The following is a description of a gene set: part of: DNA Repair This event has been computationally inferred from an event that has been demonstrated in another species.<p>The inference is based on the homology mapping from PANTHER. Briefly, reactions for which all involved PhysicalEntities (in input, output and catalyst) have a mapped orthologue/paralogue (for complexes at least 75% of components must have a mapping) are inferred to the other species. electronically inferred by orthology from the curated human pathway studied in species Mus musculus Reactome Pathway: DNA Double-Strand Break Repair, and this is the list of marker genes: Lig4, Brca1, H4c4, H2bc1, H4c12, Sumo1, H2bc3, Tdp2, Rfc1, H2bc12, H4c11 (NCBI Gene Id 319159), Smarca5, Polh, Mus81, H2bc15, Hus1, Pold4, H2bc22, H4c17, H2ax, Gen1, Rad1, Pole2, Pias4, Brca2, Rad51b, Mre11a (NCBI Gene Id 17535), H2bc8, Eya3, H2bc13, Trp53bp1, Chek2, Paxip1, Firrm (FIGNL1 interacting regulator of recombination and mitosis), Rad9a, Dna2, H4c2, Rad51c, Rbbp8, Slx4, Mapk8, Rnf4, Xrcc3, H2bc27, Prkdc, Rpa1, Rad51ap1, Ppp4r2, Nbn, Xrcc6, H2bc11, Blm, Ubb, Polq, Ercc1, Kat5, H2bc9, H4c9, Pold2, H2bc7, H4c8, Ppp4c, Palb2, Xrcc1, Ppp5c, Eya1, H4c1, Pcna, Nhej1, Apbb1, Wrn, Bard1, Polm, Rad52, Rps27a, Ube2n, Brcc3, Trp53, Polk (polymerase (DNA directed), kappa), Ercc4, Ccna1, Pole, Mdc1, Top3a, Fignl1, Slx1b, H4c6, H4c18, Rfc3, H4c3, Rnf168, Pold1 (NCBI Gene Id 18971), Babam1, Lig1, H4c14